The following is a description of a gene set: Human Gene Set: KEGG_MEDICUS_REFERENCE_TRANSCRIPTION_COUPLED_NER species: Homo sapiens Pathway Definition from KEGG: (POLR2+UVSSA) == (ERCC6+ERCC8+CRL4) -> (POLR2+UVSSA+ERCC6+ERCC8+CRL4) == (ERCC3+ERCC2) == (GTF2H) == (CAK) Transcription-coupled NER. Pathway ID: N01430. Pathway type: Reference. Pathway class: nt06502 Nucleotide excision repair., and this is the list of marker genes: POLR2D, POLR2M, POLR2J, POLR2L, GTF2H5, DDB1, ERCC6, GTF2H1, CDK7, POLR2I, POLR2E, POLR2J3, CCNH, POLR2A, GTF2H2, CUL4A, GTF2H4 (general transcription factor IIH subunit 4), ERCC2, POLR2F, ERCC3, POLR2B, MNAT1, POLR2G, UVSSA, POLR2K, POLR2J2, RBX1, POLR2C, ERCC8, GTF2H3, POLR2H